The following is a description of a gene set: Human Gene Set: GOCC_MULTIVESICULAR_BODY_INTERNAL_VESICLE A membrane-bounded vesicle wholly contained within a multivesicular body. species: Homo sapiens, and this is the list of marker genes: LRRK2, APOE, PMEL, CD63, LAPTM4B, EGFR